The following is a description of a gene set: Human Gene Set: GOCC_CYTOSOLIC_TRANSLATION_PREINITIATION_COMPLEX species: Homo sapiens A ribonucleoprotein complex that contains the small ribosomal subunit, a translation initiation ternary complex (i.e. an initiator tRNA, GTP, and an IF2 or eIF2 complex), and an mRNA., and this is the list of marker genes: EIF3H, EIF1B, EIF1, EIF3E, EIF3G, EIF1AX, EIF3I, EIF3D, EIF3L, EIF3J, EIF3B, EIF3CL, EIF3M (NCBI Gene Id 63319), DHX29, EIF2S1, EIF3F (NCBI Gene Id 8665), EIF3K, EIF3A, EIF3C (NCBI Gene Id 8663)